Given this list of marker genes RHBDD2, LINC02539, SULT2A1 (sulfotransferase family 2A member 1), WHRN, SVIL-AS1, GASK1B-AS1, LINC02045, UTS2, GNS, KLHDC8B, CYP11A1, GRIN2C, POR, SLC2A14, DHCR7, SPINK13, GALC, CYP21A2, SH3BP5-AS1, LINC02237, LINC01778, TNXB, INHA, FOXK2, SNCG, TNXA, CYB5B, PLB1, CYP11B1, HMGCR, JAKMIP2, PPP2R1A, MRAP, PTPRVP, HSPE1, TBC1D8B (NCBI Gene Id 54885), ALAS1, ZNF98, CLEC4GP1, LINC01252, ENSG00000233581, STAR, RDH12, LINC01471, SLC46A3, SLC47A1, OTOA, LDLR, USB1, FDXR, GRAMD1B, RNA5SP450 (NCBI Gene Id 100873695), ZNF275, GSTA12P, CASP9, DCAF10, GSTA9P, BBS2, SLC16A9, CIDEB, LINC02732, PAPSS2, MSMO1, DHCR24, MC2R, SCARB1, AGRP, LIPE, OR7A5, CYP17A1, ALDH3A2, NPC1, GSTA4, SH3BP5, LINC01485, SNORA59B, OGFOD1, OSGIN1, GNRHR, ENSG00000257732, GML, FDX1, SCAP, HSPD1, AQP11, MOB4, NR0B1, LINC01807, LINC03099, here is a description of the gene set: species: Homo sapiens Human Gene Set: DESCARTES_MAIN_FETAL_ADRENOCORTICAL_CELLS The gene expression program underlying the specification of human cell types is of fundamental interest. The study authors generated human cell atlases of gene expression and chromatin accessibility in fetal tissues. For gene expression, the study authors applied three-level combinatorial indexing to >110 samples representing 15 organs, ultimately profiling ~4 million single cells. The study authors leveraged the literature and other atlases to identify and annotate hundreds of cell types and subtypes, both within and across tissues. Our analyses focused on organ-specific specializations of broadly distributed cell types (such as blood, endothelial, and epithelial), sites of fetal erythropoiesis (which notably included the adrenal gland), and integration with mouse developmental atlases (such as conserved specification of blood cells). These data represent a rich resource for the exploration of in vivo human gene expression in diverse tissues and cell types. Marker genes curated from the annotated cluster as represented in the Descartes Human Gene Expression During Development database. from publication Cao J, O'Day DR, Pliner HA, Kingsley PD, Deng M, Daza RM, Zager MA, Aldinger KA, Blecher-Gonen R, Zhang F, Spielmann M, Palis J, Doherty D, Steemers FJ, Glass IA, Trapnell C, Shendure J (PMID 33184181)